Given this list of marker genes Dlg5, Por, Tubd1, Rab34, Gas8, Ulk3, Tedc2, Gpc3, Ctnna1, Intu, Pdcl, Txndc15, Uchl5, Ndst1, Armc9, Ihh (Indian hedgehog), Scube3, Gli1, Fgf9, Smo, Prrx2, Gas1, Prrx1, Sfrp1, Tedc1 (NCBI Gene Id 279769), Shh, Shox2, Cibar1, Stk36, Foxa1, Ttc23, Evc, Dhh, Gorab, Dync2h1, Wnt9a, Ift172, Isl1, Scube2, Skor2, Foxa2, Kif7, Chsy1, Scube1, here is a description of the gene set: Mouse Gene Set: GOBP_POSITIVE_REGULATION_OF_SMOOTHENED_SIGNALING_PATHWAY studied in species Mus musculus Any process that activates or increases the frequency, rate or extent of smoothened signaling.